Given this list of marker genes HBB, HDC, RGS2, HBA1, S100B, CYP1B1, CLC, HBG1, PLXNC1, LTB, here is a description of the gene set: from publication Tonks A, Pearn L, Musson M, Gilkes A, Mills KI, Burnett AK, Darley RL (PMID 17898786) Human Gene Set: TONKS_TARGETS_OF_RUNX1_RUNX1T1_FUSION_SUSTAINED_IN_MONOCYTE_DN Genes down-regulated by RUNX1-RUNX1T1 fusion protein in normal hematopoietic progenitors; their expression was sustained in subsequently developing monocytes. species: Homo sapiens The t(8;21)(q22;q22) occurs frequently in acute myelogenous leukaemia and gives rise to the transcription factor fusion protein, RUNX1-RUNX1T1 (also known as AML1-ETO). To identify the genes dysregulated by the aberrant transcriptional activity of RUNX1-RUNX1T1, we used microarrays to determine the effect of this mutation on gene expression in human progenitor cells and during subsequent development. Gene signatures of these developmental subsets were very dissimilar indicating that effects of RUNX1-RUNX1T1 are highly context dependent. We focused on gene changes associated with the granulocytic lineage and identified a clinically relevant subset of these by comparison with 235 leukaemia patient transcriptional signatures. We confirmed the overexpression of a number of significant genes (Sox4, IL-17BR, CD200 and gamma-catenin). Further, we show that overexpression of CD200 and gamma-catenin is also associated with the inv(16) abnormality which like RUNX1-RUNX1T1 disrupts core binding factor activity. We investigated the functional significance of CD200 and gamma-catenin overexpression in normal human progenitor cells. The effect of IL17 on growth was also assessed. Individually, none of these changes were sufficient to recapitulate the effects of RUNX1-RUNX1T1 on normal development. These data provide the most comprehensive and pertinent assessment of the effect of RUNX1-RUNX1T1 on gene expression and demonstrate the highly context-dependent effects of this fusion gene.